Given this list of marker genes HES1, RHOA, METTL3, METTL14, GLI3, LEF1, here is a description of the gene set: species: Homo sapiens Human Gene Set: GOBP_FOREBRAIN_RADIAL_GLIAL_CELL_DIFFERENTIATION The process in which neuroepithelial cells of the neural tube give rise to radial glial cells, specialized bipotential progenitors cells of the forebrain. Differentiation includes the processes involved in commitment of a cell to a specific fate.